Given this list of marker genes HIP1R, SGK1 (serum/glucocorticoid regulated kinase 1), KCNQ1, SCT, TFF2, PTGER3 (prostaglandin E receptor 3), NMU, here is a description of the gene set: Human Gene Set: GOBP_REGULATION_OF_GASTRIC_ACID_SECRETION Any process that modulates the rate frequency or extent of gastric secretion. Gastric secretion is the regulated release of gastric acid (hydrochloric acid) by parietal or oxyntic cells during digestion. studied in species Homo sapiens